The following is a description of a gene set: studied in species Mus musculus Mouse Gene Set: GOBP_VITAMIN_D_RECEPTOR_SIGNALING_PATHWAY A nuclear receptor-mediated signaling pathway initiated by vitamin D binding to an intracellular receptor of the nuclear receptor protein family, and ending with regulation of a downstream cellular process, e.g. transcription., and this is the list of marker genes: Mn1, Rxra, Rxrb, Trim24, Snai2, Vdr, Kank2, Med1, Pim1, Snw1, Cyp27b1, Gprin3